The following is a description of a gene set: Human Gene Set: GOBP_INTERLEUKIN_12_PRODUCTION The appearance of interleukin-12 due to biosynthesis or secretion following a cellular stimulus, resulting in an increase in its intracellular or extracellular levels. studied in species Homo sapiens, and this is the list of marker genes: CLEC7A, TLR8, MEFV, MAST2, TLR3, MAPK14, LAPTM5, HLA-G, CCR7, SLAMF1, THBS1, IL10, IRF8, LILRB1, UNC93B1, TLR2, FOXP1, MAPK11, IFNG, AGER, TNFSF4, RELA, HSPD1, JAK3, MIR21, CD36, ACP5, IRF1, TIGIT, RIPK2, MDK, TRAF6, LTB, CD47, TIRAP, LEP, PIBF1, IL23R, PLCB1, IL23A (interleukin 23 subunit alpha), IL17A, CD40LG, IRF5, LILRA5, IL16, IDO1, SYK, CCL19, IRAK3, CD40 (CD40 molecule), C1QBP, PLCG2, ISL1, HMGB1, DEFB124 (defensin beta 124), NFKB1, SCIMP, LGALS9, CMKLR1, IL12B (NCBI Gene Id 7907), HLA-B, ARRB2, TLR9, TLR4